Given this list of marker genes LSR, MSR1, PLA2G7, LPA, SAA4 (serum amyloid A4, constitutive), LCAT, APP, APOM, APOA1, SAA1, APOE, PLTP, CLU, PON1, PEX3, APOA4 (NCBI Gene Id 337), APOA5, DBI, LPL, APOF, CETP, APOC3, SAA2, APOC2, APOO, VLDLR, APOC4, APOC1, HDLBP, BIN1, APOL1, APOB, PCYOX1, HPR, SELENOS, APOA2, APOH, LIPC, LDLR, APOBR, here is a description of the gene set: species: Homo sapiens Human Gene Set: GOCC_PROTEIN_LIPID_COMPLEX A macromolecular complex containing separate protein and lipid molecules. Separate in this context means not covalently bound to each other.